The following is a description of a gene set: Mouse Gene Set: GOBP_N_TERMINAL_PROTEIN_AMINO_ACID_MODIFICATION studied in species Mus musculus The alteration of the N-terminal amino acid residue in a protein., and this is the list of marker genes: Naa80, Pdf, Ep300, Naa12 (NCBI Gene Id 117903916), Hhat, Naa16 (N(alpha)-acetyltransferase 16, NatA auxiliary subunit), Naa50, Map6d1, Metap2, Ntmt2, Sox4, Hhatl, Naa15, Naa60, Kat2b, Ppm1a, Crebbp, Naa20, Ppm1b, Ntmt1, Nmt1, Aanat, Naa11, Nmt2, Naa10